Given this list of marker genes Rigi, Oasl1, Pde12, here is a description of the gene set: electronically inferred by orthology from the curated human pathway part of: Antimicrobial mechanism of IFN-stimulated genes This event has been computationally inferred from an event that has been demonstrated in another species.<p>The inference is based on the homology mapping from PANTHER. Briefly, reactions for which all involved PhysicalEntities (in input, output and catalyst) have a mapped orthologue/paralogue (for complexes at least 75% of components must have a mapping) are inferred to the other species. species: Mus musculus Reactome Pathway: OAS antiviral response